The following is a description of a gene set: The orderly movement of a myoblast from one site to another, often during the development of a multicellular organism. A myoblast is a cell type that, by fusion with other myoblasts, gives rise to the myotubes that eventually develop into skeletal muscle fibers. species: Homo sapiens Human Gene Set: GOBP_MYOBLAST_MIGRATION, and this is the list of marker genes: SIX4, ANXA1 (NCBI Gene Id 301), MSTN, ROCK1, BIN3, AKIRIN1, NET1, THBS4, SMO, PLEKHO1, ITGB1BP1, SIX1, MEGF10